The following is a description of a gene set: Hypertrophy model species: Mus musculus Mouse Gene Set: WP_HYPERTROPHY_MODEL, and this is the list of marker genes: Myog, Nr4a3, Hbegf, Ccn1, Wdr1, Zeb1, Ifrd1, Mstn, Dusp14, Vegfa, Eif4ebp1, Il18 (NCBI Gene Id 16173), Ifng, Eif4e, Atf3, Il1a, Adam10, Il1r1, Jund